Given this list of marker genes SEC31A, PGGT1B, CELF3, PI4K2A, ZNF286A, SCN3A, CLN5, EVPL, RANGRF, HOXA3 (NCBI Gene Id 3200), CPSF7, FN1, UBE4B, POLR2M, SMPD3, IL18BP, NFATC4, SOBP, NSG2 (NCBI Gene Id 51617), GSK3A, ASPH, BBOF1, RPL36AL, PPARGC1A, RNF152, KCNE5, DGKZ, TRAF4, VGF, ARPC1A, HSPE1, RYR1, BRINP3, RPS27L, TSC1, ANK3, ARMC8, GPATCH4, NFS1, TRPM7, THOC6, MMP14, SCAMP3, TMEM100, GRIN2B, XPR1 (xenotropic and polytropic retrovirus receptor 1), SLC17A3, TIMM10B (NCBI Gene Id 26515, translocase of inner mitochondrial membrane 10B), LVRN, SCAMP2, IAPP, PVALB, SLC25A4 (NCBI Gene Id 7872), MGAT2, PTBP3 (polypyrimidine tract binding protein 3), PDE11A, SLC41A2, BBS1, MRPL45, ZFYVE27, NDP, FIBP, ARFIP2, DLX4, ORMDL2, LMAN2, SERINC2, SLC38A5, ACBD3, PI4KB, NFYB, RTN1, SLC7A13, LAPTM4B, DNAJA2, PSMD3, ANXA7, NOL4L, SCRG1, ZNF180, POF1B, MYL11, PROS1, AMBN, NPAS2, AATF, CDH1, PLA2G4F, UBE2L3, EIF3D, RBM41, WDFY4, ATXN7L2, UBE2Z, RARB, TUT1, SREK1, THPO, GPR142, RFFL, SIX1, NR4A3, IL22, GRHL2, DZIP1, ZNF462, ENPP2, GASK1B, NETO1, SKA2, SEMA6A (semaphorin 6A), GOLPH3L, HOXD11, BACH2, C1orf122, MGAT4C, FGFR2, CBL, RPS6KA3 (ribosomal protein S6 kinase A3), JPH2, CTTNBP2NL, ARHGEF3, VNN3P, ARHGEF6 (NCBI Gene Id 9459), TCEA2, THRA, KCNQ1DN, DMD, CISH, ANKS1A, PPP1R9B, ERI1, PDCD6IP, BIN3, PTCH2, TTYH1, HSD3B7, RNASE11, ELMO1 (engulfment and cell motility 1), TNFSF11, SLC4A10, PCSK2, ST6GALNAC5, LEP (leptin), TPI1P2, IWS1, PPP1R13B, KCNJ8, MKRN1, DRC7, IFT43, GEN1 (GEN1 Holliday junction 5' flap endonuclease), HCAR1, SEC14L2, ABCC5, NFIA, DNAJC5B, SLC6A10P, FOSB, WNT1, JADE1, FAM13C, CYRIA, F9, PRR11, SPEF1, SDHAF2, ARF3, ABCD4, CLU, DGKH, NEK6, MED25, IRF4, EIF4E, ADD3, IRF2 (NCBI Gene Id 3660), CD40LG, NLRP10, ING2, TNS2, PPARGC1B, UQCRFS1, RBM39, TNPO3, TLK1, ARHGAP36, SSBP4, NTRK3, ETV5 (ETS variant transcription factor 5), MMP3 (matrix metallopeptidase 3), SPEG, PLPP6, CDC14B, DQX1 (DEAQ-box RNA dependent ATPase 1), VPS53 (NCBI Gene Id 55275), SMC6, TMTC4, HCFC1R1, ZNF485, UBE2H, PRDM1, CCDC85B, SLAMF1, GJA5, AGAP2, FLRT3 (NCBI Gene Id 23767), TNIP3, POU4F1, S1PR1, FOSL2, IRX4, ZBTB9, CSF2, ALKBH6, BSN, HYOU1, SNX15, RARA, IFIH1, SERTAD3, LSAMP (NCBI Gene Id 4045), LMO4, TET2, CFAP299, QPCT, APBA1, JPH3, PRICKLE1, TCF21, ACTR1B, COX5B, NDST2, CPNE8, ECEL1, CCL20, PTHLH, BCL6, ZRANB1, MOXD1, KXD1 (NCBI Gene Id 79036), NLRP4, CACNB3, EYA1, CD247, PPP2R3A, COQ8B, CREM, NKX2-3, TOPORS, CAMSAP1 (calmodulin regulated spectrin associated protein 1), UTP14A, CSMD3, HSPD1, ROCK1, FBXW7, PHACTR3, YRDC, AGL, ZMYM3, TCERG1, SIX4, CALD1, here is a description of the gene set: Human Gene Set: STAT_Q6 Genes having at least one occurrence of the motif NNNNNTTCTKGGA in the regions spanning 4 kb centered on their transcription starting sites. This matches the transcription factor binding site V$STAT_Q6 (v7.4 TRANSFAC). species: Homo sapiens